Given this list of marker genes SLC27A6, SLC27A3, ACSL4, ACSL5, SLC27A1, ACSBG2, SLC27A4, ACSL6, SLC27A2, ACSL3, ACSL1, here is a description of the gene set: Catalysis of the reaction: arachidonate + ATP + CoA = AMP + arachidonoyl-CoA + diphosphate + H+. Human Gene Set: GOMF_ARACHIDONATE_COA_LIGASE_ACTIVITY species: Homo sapiens